Given this list of marker genes BNIP2, RUFY1, ARL6IP6, CSF3R, BLVRB, YIPF6, G6PD, TMEM179B, APIP, DIAPH3, CPQ, MTMR4, SEMA4G, CLDN9, GOLGA7, DYNLT1, EPB41L2, ABCC5, RASGRP3, CA2, ATP6V0B, MDM1, NFXL1, STK3, TNS4, MXI1, NUP205, RIN2, PRF1, VWA5A, PCTP, RAF1, MAP3K5, ARRDC3 (arrestin domain containing 3), CAPNS1, HYCC1, OASL, RENBP, GUSB, NFIX, SMOC2, SCD, FAM43A, NFIC, SLC25A39, NHSL2, SLC15A4, IL31RA, SLC6A6, SPRY2, ARHGAP30, KLRD1 (killer cell lectin like receptor D1), MPC2, CHML, CRTAM, FHL5, KBTBD7, ATL2, HEXB, ARSK, SNX10, CEBPB, NIPSNAP3A, CIP2A, ARL4D, SDF2L1, MPP1, CD2AP, LIMD1, CLDN15, PALS2, PLEKHM3, TOB2, PSMD14, OSBPL8, ARSB, ANLN, RBM47, LMF1, RTN1, MAPKAPK2, TMEM208, GRINA, MEF2D, BIN3, NFKBIZ, PTPRC, ITCH, NAGPA, WDR3, LRRK1, ITPRIPL2, OSBPL3, CAMK1, ADIPOR1, ILRUN, TMEM176B, MFSD5 (NCBI Gene Id 84975), TOR1AIP1, CRCP, ITGA4, NR2F2, NXT2, YWHAB, KLHL4, HES1, MAP7D1, MIR22HG, REL, PTPN12, SANBR, MAVS, ZDHHC24 (NCBI Gene Id 254359), E2F7, CMPK1, PAPSS1, TM6SF1, TET2, COPRS, KANSL1L, CAMKK2, NKIRAS2, MSN, LRP4 (LDL receptor related protein 4), CNIH4, VPS50, CYBA, ZNF839, MLKL, GARRE1, CUZD1, EHBP1L1, KIAA1191, SMU1, MAPKAP1, RFC2 (NCBI Gene Id 5982), HOOK3, TMEM38B, LAX1, FAR1, DHRS3, CTBS, PPP2R5A, YWHAZ, TMED5, BRK1, LIMS4, UCP2, AZIN2, PHYH, DBI, MAPK14, ALPK1, C1orf21, MKNK1, LTBR, STAG2, TM9SF2, NABP1, BET1, MSRA, EML3, GGA2, CASP3, NUP188, CD72, PRXL2C, CNPY3 (canopy FGF signaling regulator 3), CRYZL1 (NCBI Gene Id 9946), SNAP23, JARID2, MAP3K8, SEMA5B, MBNL2, MIA2, NDST2, TALDO1, SLC45A3, ATG3, LINC01973 (NCBI Gene Id 400624), HPS5, UBAP1, SUMF1 (sulfatase modifying factor 1), FAM135A, PICALM, SCARA3, NUSAP1, TFEB, FMNL3, PBX1, GEM, UBAC2, VPS26A, MAML1, SLC25A45, CDC40, ITGB2, EXOC3, ITM2B, OST4, here is a description of the gene set: Genes down-regulated in comparison of CD4 T cells versus NK cells. from publication Konuma T, Nakamura S, Miyagi S, Negishi M, Chiba T, Oguro H, Yuan J, Mochizuki-Kashio M, Ichikawa H, Miyoshi H, Vidal M, Iwama A (PMID 21540074) studied in species Homo sapiens Human Gene Set: GSE27786_CD4_TCELL_VS_NKCELL_DN Each fraction of mouse hematopoietic cells was purified by cell sorting from bone marrow of 8-week-old C57BL/6 mice, and its gene expression was analyzed.